Given this list of marker genes SLC22A6, SLC22A8, SLC22A12, SLC22A11, SLC22A7, here is a description of the gene set: studied in species Homo sapiens Organic anion transport Human Gene Set: REACTOME_ORGANIC_ANION_TRANSPORT